Given this list of marker genes CALD1, BMP1, ATP2B4, TAGLN, WASHC3, TIMP3, GOLGA8F, BHLHE40, PDXK, CDH4, SERPINE1, LAMP2 (lysosomal associated membrane protein 2), PALLD, IGFBP3, ADCY7, GSDME, JUNB, NPTX1 (neuronal pentraxin 1), EVL, C1S, GADD45B, MYL9, SLC22A5, ECE1, JAK1, SLC16A4, FERMT2, CCN5, ITGAV, WIPF1, COL4A1, PGLS, OGA, SGK1, MSC, NCK2, COL5A1, HGD, NLRP1, HSPB1, SPARC, DENND2B, CHST3, ADGRG1, JUN, DICER1, ADAM19, TPM1 (NCBI Gene Id 7168), TCIM, HSPG2, LBH, SOX4, INPP4B (inositol polyphosphate-4-phosphatase type II B), EPHB2, COL1A1, COL4A2, CADM1, SPOCK1, MATN2, ULK1, CLDN4, DNAJB2, TGFB2, FLRT2, RSU1, GABARAPL1, IGFBP7, PMEPA1, TNS1, TGFBI, ACVR1B, SERPINE2, GLIPR1, NCF2, COL7A1, DKK3, ACKR3, SNAI1, NUAK1 (NUAK family kinase 1), TUFT1, CCL2, P4HA2, MAP3K8, here is a description of the gene set: studied in species Homo sapiens Using advanced gene targeting methods, generating mouse models of cancer that accurately reproduce the genetic alterations present in human tumors is now relatively straightforward. The challenge is to determine to what extent such models faithfully mimic human disease with respect to the underlying molecular mechanisms that accompany tumor progression. Here we describe a method for comparing mouse models of cancer with human tumors using gene-expression profiling. We applied this method to the analysis of a model of Kras2-mediated lung cancer and found a good relationship to human lung adenocarcinoma, thereby validating the model. Furthermore, we found that whereas a gene-expression signature of KRAS2 activation was not identifiable when analyzing human tumors with known KRAS2 mutation status alone, integrating mouse and human data uncovered a gene-expression signature of KRAS2 mutation in human lung cancer. We confirmed the importance of this signature by gene-expression analysis of short hairpin RNA-mediated inhibition of oncogenic Kras2. These experiments identified both a pattern of gene expression indicative of KRAS2 mutation and potential effectors of oncogenic KRAS2 activity in human cancer. This approach provides a strategy for using genomic analysis of animal models to probe human disease. Genes upregulated in KRAS knockdown vs control in a human cell line. from publication Sweet-Cordero A, Mukherjee S, Subramanian A, You H, Roix JJ, Ladd-Acosta C, Mesirov J, Golub TR, Jacks T (PMID 15608639) Human Gene Set: SWEET_KRAS_TARGETS_UP